Given this list of marker genes Vcp, Slc52a3, Flad1, Rfk, Slc52a2, here is a description of the gene set: species: Mus musculus The chemical reactions and pathways involving a flavin, any derivative of the dimethylisoalloxazine (7,8-dimethylbenzopteridine-2,4(3H,10H)-dione) skeleton, with a substituent on the 10 position. Mouse Gene Set: GOBP_FLAVIN_CONTAINING_COMPOUND_METABOLIC_PROCESS